The following is a description of a gene set: species: Homo sapiens Proton-coupled monocarboxylate transport Human Gene Set: REACTOME_PROTON_COUPLED_MONOCARBOXYLATE_TRANSPORT, and this is the list of marker genes: BSG, SLC16A8, EMB, SLC16A7, SLC16A1, SLC16A3